Given this list of marker genes PTGDR2, PTGDS, CIB1, RHBDD1 (NCBI Gene Id 84236), EIF2S2, UCHL1, HPGDS, FANCA, PRDX4 (peroxiredoxin 4), DMRT1, here is a description of the gene set: studied in species Homo sapiens The multiplication or reproduction of germ cells, reproductive cells in multicellular organisms, resulting in the expansion of a cell population. Human Gene Set: GOBP_GERM_CELL_PROLIFERATION